Given this list of marker genes GLO1, MRPS18B, KIF23, AK4, HNRNPK, COQ3, WDR77, BTF3, CDCA7 (cell division cycle associated 7), EIF3I, SDHD, DAP3, HNRNPAB, PSMB6, CHEK2, EIF4A1, RUVBL1 (NCBI Gene Id 8607), GNL3, PLK1, PDHA1, NHP2, DLAT, PHC1, ANP32E, XRCC5, NT5DC2 (NCBI Gene Id 64943), RPS23, RRM1, RUVBL2, CCNB2, CKS2, PRIM1, NTHL1, RPL10A, RPL13, MID1IP1, KIF4A, GSPT2, CDC6, RFC3, PSMA5 (proteasome 20S subunit alpha 5), GNA14, NCBP2, CDCA5 (cell division cycle associated 5), CRABP2, BCAT1, CTNNA1, ZIC3, MRPL11, MRPL39, MRPL4, VBP1, TRIP6, TIMM44, RAD23B, UQCR11, SDHC, TOP2A, RPS3, JPT1, LSM4, STOML2, TRIP13, EIF4B, MCM7, MRPL15, MSH2, ERP29, RPS5, NME4, HAUS1, EIF2S2, MRPL16, MCM4, MYBL2, NLN, TGIF1, RAD18, SARS1, SSB, CDK1, TERF1, RPL27A, ACAD8, SLC16A1, DTL, SMC2, WEE1, SNRPA1, SEPHS2, GJA1, CYCS, BIRC5, NDUFB8, NDUFA11 (NCBI Gene Id 126328), SINHCAF, THOC3, TMEFF1 (NCBI Gene Id 8577), RACGAP1, MRTO4, TTK, NASP, MRPS30, CHEK1, RPSA, FGFR1, ALDH7A1, LBHD1, KPNA6 (karyopherin subunit alpha 6), ERCC6L, EIF3L, NCAPH, SMC4, TCOF1, ELOVL6, NUSAP1 (NCBI Gene Id 82534), PPM1G, GTSE1, PA2G4 (proliferation-associated 2G4), SERPINH1, GARS1, IPO9, BANF1, NDUFA9, TIMM13, CDCA3, HAT1, DARS2, PPP4C (NCBI Gene Id 5531), E2F3, ABCB7, CKAP2, ORC1, LSM5, MTHFD2, EEF2, NCAPD2, CCNA2, GMNN, RPS27, UGDH, SNRPA, SLC2A1, NDUFAB1, MAIP1, HMGB2 (high mobility group box 2), COX5B, SS18, EIF3K, ALDOC, SNRPD1, BUB1, NME2, PHB1, NEK2, GEMIN2, EIF6, UBE2V2, KPNA2, NAP1L1, IARS1, KIF22, DHX9, HSPA9, CSRP2, ADSL, MRPS17, MRPL12, ECHS1, LSM2, TIMM8B, PRPS1, RPA3, EIF3A, MCM2, HMGN5, PSME3, KIF11, CCND2, VRK1, KGD4, ETFA, GNPDA1, NDC80, PRDX1, CDK4, RPL22, MCM5, SLC25A5, CCNC, OTX2, RPS12, POLD1, GART, WBP11, MRPS2, GLDC, EBNA1BP2, FAM136A, RNPS1, AURKB, NONO, BUB3, DBF4, LSM10, RAB34, CDC34, XPO1, BAX, YY1, DNMT1, EMC8 (NCBI Gene Id 751), MTF2, PDIA4, PARP1, PSMA7 (proteasome 20S subunit alpha 7), CISD1, PCNA, HELLS, DPP3, G3BP1, TCF7L1, PDCD2, WDHD1, PHF5A, PROM1, CTSC, TIMM8A, PRMT1, NUDCD2, STIP1, EXO1, SOX2, SUMO1, ATP5PO, ADH5, HDAC1, FDPS, MRPL13, ZNF22, RPP40 (NCBI Gene Id 10799), CDKN1C, NDUFB7, TCF19, CSE1L, AURKA, RRM2, BLM, LMNB1, CKS1B, NOP10, EIF2S3, SPAG5, DEK, UTP18, PIPOX, POP7, POLR2F, EXOSC7, EIF4EBP1, RPA2, HNRNPL, RCC1, CLPP, FH, EEF1E1, HSPA14, RPS19, NOP2, CDCA8, BUB1B, CCT5, NIPSNAP1, SNRNP40, KIF20A, CBX3, CDC20, TEAD2, HADH, CHAF1A, POLE2, NUP107, SRSF10, MAPK13, HNRNPA1, PLK4, RCN2, PDPN, RPS8, PUS1, NDUFB10, SQLE, ENO1, FBL, TP53, ATP5PF, U2AF1, APEX1, PSMB5, PRIM2, CCNF, PRMT3, RCC2, LYPLA1, NCL, RPS16, FARSA, NIP7, NDUFS2, MRPS28, PSMD14, PABPC1, NIFK (nucleolar protein interacting with the FHA domain of MKI67), KRAS, CCND1, SNX5, DDX18, POLR3K, CDKN3, MCM3, UQCRH, MAD2L1, MYC, TGIF2, UBE2G1, AMOTL2, SET, MRPL37, GEMIN6, DTYMK, DLGAP5, BRIX1, HSPE1, YAP1, CDC7, here is a description of the gene set: Self-renewal is a hallmark of stem cells and cancer, but existence of a shared stemness program remains controversial. Here, we construct a gene module map to systematically relate transcriptional programs in embryonic stem cells (ESCs), adult tissue stem cells, and human cancers. This map reveals two predominant gene modules that distinguish ESCs and adult tissue stem cells. The ESC-like transcriptional program is activated in diverse human epithelial cancers and strongly predicts metastasis and death. c-Myc, but not other oncogenes, is sufficient to reactivate the ESC-like program in normal and cancer cells. In primary human keratinocytes transformed by Ras and I kappa B alpha, c-Myc increases the fraction of tumor-initiating cells by 150-fold, enabling tumor formation and serial propagation with as few as 500 cells. c-Myc-enhanced tumor initiation is cell-autonomous and independent of genomic instability. Thus, activation of an ESC-like transcriptional program in differentiated adult cells may induce pathologic self-renewal characteristic of cancer stem cells. from publication Wong DJ, Liu H, Ridky TW, Cassarino D, Segal E, Chang HY (PMID 18397753) Human Gene Set: WONG_EMBRYONIC_STEM_CELL_CORE species: Homo sapiens The 'core ESC-like gene module': genes coordinately up-regulated in a compendium of mouse embryonic stem cells (ESC) which are shared with the human ESC-like module.